Given this list of marker genes Slc22a2, Slc25a18, Slc6a19, Slc6a13, Slc25a22, Slc6a7, Slc6a3, Slc6a2, Slc6a1, Slc17a7, Slc17a8, Slc22a1, Slc6a9, here is a description of the gene set: electronically inferred by orthology from the curated human pathway species: Mus musculus part of: SLC-mediated transmembrane transport Reactome Pathway: SLC-mediated transport of neurotransmitters This event has been computationally inferred from an event that has been demonstrated in another species.<p>The inference is based on the homology mapping from PANTHER. Briefly, reactions for which all involved PhysicalEntities (in input, output and catalyst) have a mapped orthologue/paralogue (for complexes at least 75% of components must have a mapping) are inferred to the other species.